The following is a description of a gene set: The directed movement of fructose into, out of or within a cell, or between cells, by means of some agent such as a transporter or pore. Fructose exists in a open chain form or as a ring compound. D-fructose is the sweetest of the sugars and is found free in a large number of fruits and honey. Mouse Gene Set: GOBP_FRUCTOSE_TRANSMEMBRANE_TRANSPORT studied in species Mus musculus, and this is the list of marker genes: Slc2a8, Slc26a5, Slc2a3, Slc2a9, Slc2a2, Slc5a10, Slc2a7, Slc2a5